The following is a description of a gene set: Three innate (B1-B, NKT, CD8aaT cells) and adaptive (B2-B, CD4T, CD8abT cells) cell-types were sorted by FACS. Three biological replicates for NKT, CD4T, CD8aaT, CD8abT cells and two biological replicates for B1 and B2 cells were generated and the expression profiles were determined using Affymetrix Mu74Av2 chip. Comparisons between the sample groups allow the identification of genes differentially expressed between the innate and adaptive cell-types. studied in species Homo sapiens Genes up-regulated in CD4 T cells versus B1 B lymphocytes. Human Gene Set: GSE3039_CD4_TCELL_VS_B1_BCELL_UP from publication Yamagata T, Benoist C, Mathis D (PMID 16623764), and this is the list of marker genes: PHKA1, STXBP1, SULF2, EIF4H, GALNT1, TRIM28, DCTN1, MLEC, LPL (NCBI Gene Id 4023), CFHR1, BAD, PKP3, MDH2 (NCBI Gene Id 4191), ASB2, WDHD1, OASL, ROGDI, TACC2, ATP6V0E2, TUBA1B, MYADM (NCBI Gene Id 91663), NAPSA, ALOX15, GSN, TEP1, ASGR2, SLAMF9, TSPYL5, TP53I11, IL1RL1, CNTD1, HLA-DRB1, UACA, NUP107, NCS1, ARRDC1, KIDINS220, ADRA2A, RPN1, SHFL (shiftless antiviral inhibitor of ribosomal frameshifting), OLFM1, SIGLEC10, HLA-DMB, GGACT, PAQR4, CD34, CIAPIN1 (cytokine induced apoptosis inhibitor 1), C8orf34, ZYX, CCDC81, IFIT1B, RAB39A, CBFA2T3, C1QA, AKAP1, JUND, AMER1, LTBP3, TTC21A, NDUFV3, CRIP1, TTC21B, TANC2, NME1, SMTN, PLCB3, DBNL, METRN, IPO13, MBNL1, FKBP1A, HR, NCAPH, EPB41L3, COX10, JAK2, TLE1, TAGLN2, UBE2S (ubiquitin conjugating enzyme E2 S), HYOU1, ITGAX, WRN, ATP8B2, CST11, CDH17, HTR7, TONSL, MEGF8, RNASE2, FGFR1, COX7A2L, BAZ1B, CD69, RASL11B, CMIP, CEP89, HROB, CCT3, ARL2BP, AKR1C3, KCTD17, FAM81B, MBD5, FLNB, CIITA, AP2B1, APLNR, RPL3, CD74, ELOVL5, PDIA6, SEC16A, PCLAF, SELP, LEF1, PF4, ZNF385A, AKR7A2, ZNF622, METTL2B, LPCAT1, CKB, KDM2B, CDK12, GATAD2B, NOP53, CCL17 (NCBI Gene Id 6361), EMD, MPHOSPH9, CARD10, IL2RA, GM2A, IFI30, AKR1B1, GYS1, CREB3L2, PELP1, MYL2, RAB7A, RNASE3, RTN1, SNRPB, CTTN, PRDX2, HORMAD1, CCDC80, ITGAE, MYCL (NCBI Gene Id 4610), PALLD, LY86, ST3GAL5, UBE2O, GDI2, DKKL1, ARHGAP19, KMO, MFAP1, HNRNPC, FRMD6 (FERM domain containing 6), CDKL4, FN1, PTPRR, USP39, AKAP11, CAMP, HLA-DQA1, CCND1, TNS4, EEF1G, PIM3, PITPNB, IL20RB, TRAF3IP1, STK32C, SLC2A3, H1-4, MMP12, OAZ1, FAM168A, CCR2, IGFBP4, MARVELD1, FARS2, CARMIL1, CLEC10A, CYP1B1, C1orf21, PTP4A2, SDC3, FNDC5, ITPR2, MS4A6A, IFITM3 (NCBI Gene Id 10410), PIGQ (NCBI Gene Id 9091), HIC1 (NCBI Gene Id 3090), AHCYL2, DNAAF11, P4HB, POLL, CST3